The following is a description of a gene set: species: Homo sapiens A single cancer cell contains large numbers of genetic alterations that in combination create the malignant phenotype. However, whether amplified and mutated genes form functional and physical interaction networks that could explain the selection for cells with combined alterations is unknown. To investigate this issue, we characterized copy number alterations in 191 breast tumors using dense single nucleotide polymorphism arrays and identified genes with copy number gain organized into 30 amplicons. Amplicons were distributed unequally throughout the genome. Each amplicon had distinct enrichment pattern in pathways, networks, and molecular functions, but genes within individual amplicons did not form coherent functional units. Genes in amplicons included all major tumorigenic pathways and were highly enriched in breast cancer-causative genes. In contrast, genes with somatic mutations in breast cancer were distributed randomly over the genome, did not represent a functionally cohesive gene set, and were relatively less enriched in breast cancer marker genes. Mutated and gained genes did not show statistically significant overlap but were highly synergistic in populating key tumorigenic pathways including transforming growth factor beta, WNT, fibroblast growth factor, and PIP3 signaling. In general, mutated genes were more frequently upstream of gained genes in transcription regulation signaling than vice versa, suggesting that mutated genes are mainly regulators, whereas gained genes are mostly regulated. ESR1 was the major transcription factor regulating amplified but not mutated genes. Our results support the hypothesis that multiple genetic events, including copy number gains and somatic mutations, are necessary for establishing the malignant cell phenotype. Genes within amplicon 14q22 identified in a copy number alterations study of 191 breast tumor samples. Human Gene Set: NIKOLSKY_BREAST_CANCER_14Q22_AMPLICON from publication Nikolsky Y, Sviridov E, Yao J, Dosymbekov D, Ustyansky V, Kaznacheev V, Dezso Z, Mulvey L, Macconaill LE, Winckler W, Serebryiskaya T, Nikolskaya T, Polyak K (PMID 19010930), and this is the list of marker genes: GNPNAT1, STYX, GPR137C, FERMT2, RTRAF (NCBI Gene Id 51637), TXNDC16, PSMC6, ERO1A, NID2, PTGDR, PTGER2, DDHD1, GNG2, FRMD6